The following is a description of a gene set: studied in species Homo sapiens Any process that stops, prevents or reduces the frequency, rate or extent of organelle assembly. Human Gene Set: GOBP_NEGATIVE_REGULATION_OF_ORGANELLE_ASSEMBLY, and this is the list of marker genes: STYXL1, WDR44, EHMT2, BECN1, SEC22B, MAP4, USP10, RBM14, TBC1D7, MAK, NUPR1, LPAR1, MARCHF7, CCP110, FEZ1, LRRK2, TRIM32, LUZP1, KAT2A, GDI2, CDK5RAP2, KAT2B, YAP1, LIMK2, LIMA1, SMAD4, TCHP, BRCA1, CAV3 (caveolin 3), SCFD1, NBDY, MDM1, PATL2, SMCR8, KIF24, TESK1, ODF2L, CDK10, MTM1, CEP97, FEZ2, TRIM37, PHF23, MPHOSPH9, AKT1, PINK1, EVI5L, TBC1D30, TMEM39A